The following is a description of a gene set: Human Gene Set: WP_BIOSYNTHESIS_AND_TURNOVER_OF_1DEOXYSPHINGOID_BASES Biosynthesis and turnover of 1-deoxy-sphingoid bases species: Homo sapiens, and this is the list of marker genes: KDSR, SPHK1, SGPP2, SPHK2, SPTLC1, SGPP1, SPTLC2, ASAH1